Given this list of marker genes IL4R, RARA, NLRP3, IL18, CD86, TNFSF4, PRKCZ, here is a description of the gene set: Human Gene Set: GOBP_POSITIVE_REGULATION_OF_T_HELPER_2_CELL_DIFFERENTIATION Any process that activates or increases the frequency, rate or extent of T-helper 2 cell differentiation. species: Homo sapiens